The following is a description of a gene set: studied in species Homo sapiens The directed movement of cholesterol, cholest-5-en-3-beta-ol, out of a cell or organelle. Human Gene Set: GOBP_CHOLESTEROL_EFFLUX, and this is the list of marker genes: MIR613, APOA2, NR1H3, ABCA2, NR1H2, RXRA, MIR19B1, NPC1, MIR302A, PLTP (phospholipid transfer protein), APOA4, MAPK3, MIR93, APOA1, NPC2, ABCA7, NFKB1, MIR128-1, MIR27A (NCBI Gene Id 407018), STX12 (syntaxin 12), CETP, MIR206, TTC39B, ABCA1, SOAT2, APOF, SPG11, NAXE, APOC2, SCARB1, MIR301B, COMT, APOC3, LIPA, PLA2G10, MIR758, APOB, ABCA12, CAV1, SIRT1, SREBF2, APOC1, MIR130B, PTCH1, PON1, ABCA5, ABCA3, MIR27B, ABCG5, TREM2, MIR26A1, APOM, GPS2, MIR9-1, MIR17, ADIPOQ, EEPD1, ZDHHC8, APOE, MIR144, SOAT1, SHH, MIR145, ABCG8, MIR33A, MIR33B, ABCG1, ABCA8, LRP1, EGF, LAMTOR1, TSKU, YJEFN3, PPARG, APOA5, ABCG4, MIR148A, CES1